The following is a description of a gene set: Human Gene Set: STOSSI_RESPONSE_TO_ESTRADIOL from publication Stossi F, Barnett DH, Frasor J, Komm B, Lyttle CR, Katzenellenbogen BS (PMID 15033914) Genes up-regulated by estradiol (E2) in U2OS cells (osteosarcoma) expressing ESR1 or ESR2. Estrogens exert many important effects in bone, a tissue that contains both estrogen receptors alpha and beta (ERalpha and ERbeta). To compare the actions of these receptors, we generated U2OS human osteosarcoma cells stably expressing ERalpha or ERbeta, at levels comparable with those in osteoblasts, and we characterized their response to 17beta-estradiol (E2) over time using Affymetrix GeneChip microarrays to determine the expression of approximately genes, followed by quantitative PCR verification of the regulation of selected genes. Of the approximately 100 regulated genes we identified, some were stimulated by E2 equally through ERalpha and ERbeta, whereas others were selectively stimulated via ERalpha or ERbeta. The E2-regulated genes showed three distinct temporal patterns of expression over the 48-h time course studied. Of the functional categories of the E2-regulated genes, most numerous were those encoding cytokines and factors associated with immune response, signal transduction, and cell migration and cytoskeleton regulation, indicating that E2 can exert effects on multiple pathways in these osteoblast-like cell lines. Of note, E2 up-regulated several genes associated with cell motility selectively via ERbeta, in keeping with the selective E2 enhancement of the motility of ERbeta-containing cells. On genes regulated equally by E2 via ERalpha or ERbeta, the phytoestrogen genistein preferentially stimulated gene expression via ERbeta. These studies indicate both common as well as distinct target genes for these two ERs, and identify many novel genes not previously known to be under estrogen regulation. studied in species Homo sapiens, and this is the list of marker genes: GJA1, ITGA6, PPP1R12B, GRK5, AGT, NTS, F13A1, SERPINA6, LRIG1, KLRC2, ADAM3A, SELENOP, NR4A3, CCN5, HYAL1, TCN1, CXCL8, KRT19, BIRC3, PLA2G4A, NHERF1, CD34, RHOBTB3, CA12, RALA, GK3, RASGRF1, NRIP1, PDZK1, ADK, BMP6, CDH19, TFF1, DEFB1, MSMB, SPARCL1, TLE3, ACOX2, KLRC4, GREB1, IL24, KLRC3, SKIL, IL13RA2, PTGS2, OPHN1